The following is a description of a gene set: TLR5 is the receptor for flagellin, the protein that forms bacterial flagella. Unlike most other Pathogen-Associated Molecular Patterns (PAMPs), flagellin does not undergo any posttranslational modifications that would distinguish it from cellular proteins. However, flagellin is extremely conserved at its amino- and carboxyl-termini, which presumably explains why it was selected as a ligand for innate immune recognition. TLR5 is expressed on epithelial cells as well as on macrophages and dendritic cells. Expression of TLR5 on intestinal epithelium is polarized such that TLR5 is expressed only on the basolateral side of the cell, as pathogenic but not commensal microbes cross the epithelial barrier. This ensures that innate immune responses are confined to pathogenic but not commensal microbes. species: Homo sapiens part of: Toll-like Receptor Cascades Reactome Pathway: Toll Like Receptor 5 (TLR5) Cascade, and this is the list of marker genes: TAB3, TAB2, IRAK2, MAPK7, JUN, NKIRAS1 (NFKB inhibitor interacting Ras like 1), MAP3K1, DUSP4, NFKBIB, TLR10, PPP2R5D, UBB, TAB1, MAP2K6, CHUK, S100A12, TRAF6, NLRX1, ECSIT, PPP2R1A, N, IKBKG, NOD1, DUSP6, IKBIP, PPP2CB, HMGB1, SAA1, RPS6KA5, PELI3, FBXW11, CASP8, ATF1, NLRC5, IKBKB, UBC, ELK1, UBA52, USP18, MAP2K1, NFKB2, MAPK1, ALPK1, MAPK8 (mitogen-activated protein kinase 8), MYD88, RPS6KA2, RPS6KA1, NOD2, SKP1, TRAF2, MAPKAPK2, MAP2K7, MAP2K3, UBE2N, PELI1, APP (NCBI Gene Id 351), BTRC, TP53, MAP2K4, LRRC14, VRK3, RPS27A, UBE2V1, CUL1, RELA, PPP2R1B, NFKB1 (nuclear factor kappa B subunit 1), MAPKAPK3, NFKBIA, S100B, DUSP7, AGER, IRAK1, TLR5 (NCBI Gene Id 95519), CREB1, MEF2C, RIPK2, DUSP3, IRAK4, MEF2A, MAPK11, PPP2CA, MAP3K8, TNIP2, PELI2, MAPK9 (NCBI Gene Id 5601), USP14, MAP3K7 (mitogen-activated protein kinase kinase kinase 7), MAPK14, NKIRAS2, MAPK10, MAPK3, ATF2, FOS, N4BP1, TIFA, fliC, RPS6KA3